Given this list of marker genes LIN28B, ALK, LMO1, PHOX2B, MYCN (MYCN proto-oncogene, bHLH transcription factor), HACE1, RET (NCBI Gene Id 5979), KIF1B, here is a description of the gene set: studied in species Homo sapiens An increased concentration of vanillylmandelic acid in the urine. Elevated urinary vanillylmandelic acid Human Gene Set: HP_ELEVATED_URINARY_VANILLYLMANDELIC_ACID